The following is a description of a gene set: Human Gene Set: GOBP_NEUROBLAST_MIGRATION The orderly movement of a neuroblast from one site to another, often during the development of a multicellular organism or multicellular structure. A neuroblast is any cell that will divide and give rise to a neuron. species: Homo sapiens, and this is the list of marker genes: EDNRB, ABCC8, TNR, FUT10, ATOH1, SIX3